Given this list of marker genes PPP6C, PTPN18, CDC14B, CTDP1, PTPN21, PTPN4, DUSP5, PPP2CA, DUSP3, CTDNEP1, BTRC, MTMR6, PTPRC, FBXW11, PTPRR, CTDSP1 (NCBI Gene Id 58190), PTPN2, STK11, PPP3CC, MTMR3, PTPRT, PTPN12, EPM2A, MTMR7, PPP2CB, PTEN, PTPRB, PTPRS, PTPRF, PTPRE (NCBI Gene Id 5791), PTPRN2 (NCBI Gene Id 5799), PPP1CC, DUSP26, DUSP7, PPEF1, DUSP11, PTPRZ1, CTDSP2, PPM1B, PPP2R3B, DUSP21, DUSP6, DAPP1, CTTNBP2NL, PPP1CA, DUSP13B, TIMM50, PPP2R2A, PTPRJ, PPP1CB, PTPN11, PPM1A, PTPN6, PTPN5, PPP2R3A, DUSP29, PTPN9, PTPN1, DUSP9 (dual specificity phosphatase 9), DUSP18, PTPN13 (protein tyrosine phosphatase non-receptor type 13), PPM1E, PPP5C, SSH2, PTPRK, PDP1, PPM1M, PDXP, PPP1R12A, PTPRH, ACP4, PTPN7, PTPN14, SBF1, TPTE, PPP3CB, PTPRU, DUSP1, TNS2, SSH1, SDHAF2, PPP3CA, PPM1G, DUSP2, PPEF2, MTM1, PPM1D, here is a description of the gene set: species: Homo sapiens Human Gene Set: GOBP_PROTEIN_DEPHOSPHORYLATION The process of removing one or more phosphoric residues from a protein.